The following is a description of a gene set: Genes down-regulated in comparison of dendritic cells (DC) stimulated with Pam3Csk4 (TLR1/2 agonist) at 12 h versus DC cells stimulated with CpG DNA (TLR9 agonist) at 12 h. mouse primary BMDCs were stimulated with tlr ligands and gene expression changes were profiled on Affymetrix arrays from publication Amit I, Garber M, Chevrier N, Leite AP, Donner Y, Eisenhaure T, Guttman M, Grenier JK, Li W, Zuk O, Schubert LA, Birditt B, Shay T, Goren A, Zhang X, Smith Z, Deering R, McDonald RC, Cabili M, Bernstein BE, Rinn JL, Meissner A, Root DE, Hacohen N, Regev A (PMID 19729616) species: Homo sapiens Human Gene Set: GSE17721_PAM3CSK4_VS_CPG_12H_BMDC_DN, and this is the list of marker genes: APPL1, MAP2, AGRN, SNX4, LRRC8C, GGPS1, PML, SERPINB9, CARS1, MYD88, ADGRB1, OGFR, CWC22, DGUOK, ADAMTSL5, CDC27, CMTR1, MX1, ARL14EP, CPTP, CH25H, H1-2, WDR36, NFKBIZ, RNF6, EPSTI1, WFS1, SLC6A8, TIMP4, METRNL, ASPH, CCKAR, AIF1, C9orf72, WNK2, WDR48, EXTL1, MED24, KCTD14, GBP4, CPSF7, TRIM27, EVI2A, FBH1, TFAP2A, CD180, SUOX, RBM7, CACNB3, NUB1, SASS6, DNAJA1, INO80C, KLK7, TNF, INTS4, MAPK7, SDCBP, PIM1, IL17RC, TIPARP, USP25, SMAP2, KEAP1, KRT25, IL4I1, NFKBIA, RHOC, LMO2, TLR9, FZR1, PLEKHS1, CCDC80, STX2, MATN3, TLCD1, MOB4, BASP1, SRPRA (SRP receptor subunit alpha), ALCAM, TENT2, HOXA3, HCK, FUT8, KLF6, MYL7, LGALS3BP, RMDN3, ELF5, STK4, ETV3, CD70, MAZ, RTN4, GNA14, SEPTIN8, GADD45B, KRTAP20-2, PCDH12, ADRA2A, FABP4, CHST15, LCP2, DNAJA2, CCR4, CASP8, HNF4G, IL12RB1, RAB20, IL15RA, RAB22A, CST3, ANKRD24, MLF2, IKBKG, PSME4, RND3, OAS2, ARIH1, SAP30, TRIB3, SLC17A9, MCL1, NFKBIB, C11orf68, CHAC2, GPX6, CSTF3, IRF1, ARFRP1, PHYH, RNF14, ENTR1, PTGS2 (prostaglandin-endoperoxide synthase 2), GJA5, P2RY2, GPR83, CLIP1, PARP14, CCNG2, TBC1D13, GRB2, LGALS3, SST, KCNAB1, SLC22A5, EIF4ENIF1, MITD1, MORC3, TLR1, OGFRL1, GNL1, CSRP1, ZNF22, NR1D2, G6PD, LAMP5, COL2A1, PHKG1 (NCBI Gene Id 5260), POLDIP3, EXOC1, AP2B1, IGBP1, TMEM39A, PTPN2, EFR3A, C6orf120, TSPAN1, TMCO4, MAPRE2, ECE1, ATP6V1D, ZNF474, ARID5A, ABCC6, RCSD1, TBK1, MYLIP, ANKRD2, TAB2, FRYL, BST2, ANXA1, HOOK2, CD274 (CD274 molecule), CHMP4B, B3GNT2, SERPINF2, KRT85, ADAMTS4, PPP1R18, UTP11, RFC2, NUDT9, SLCO3A1, UPP1, FAM169A, B2M, CXCL9, RAP1B